The following is a description of a gene set: Mouse Gene Set: GOBP_NEGATIVE_REGULATION_OF_PROTEIN_LOCALIZATION_TO_MEMBRANE Any process that stops, prevents or reduces the frequency, rate or extent of protein localization to membrane. species: Mus musculus, and this is the list of marker genes: Ppfia1, Tmbim1, Csk, Mrap2, Mrap, Wnk1, Sfn, Rhoq, Tmed2, Cltc, Ngdn, Kcne1, Wnk4, Pid1, Cdh1, Hectd1, Abi3, Lrrc15, Wnk3 (WNK lysine deficient protein kinase 3), Picalm, Tmem59, Ap2m1, Inpp5k, Itgb1bp1, Bcl2l1 (NCBI Gene Id 12048), Usp17le, Ogt, Lypla1, Lyplal1, Tgfb1, Lztfl1, Dab2, Pkdcc, Dmtn, Gdi1, Lypd1, Numb, Gripap1, Fzd9, Ppp2r5a